Given this list of marker genes EREG, BMP15, TNFAIP6, GDF9, PTGER2, PTX3, BMPR1B, AREG, AMBP, here is a description of the gene set: studied in species Homo sapiens Human Gene Set: MATZUK_CUMULUS_EXPANSION from publication Matzuk MM, Lamb DJ (PMID 18989307) Reproduction is required for the survival of all mammalian species, and thousands of essential 'sex' genes are conserved through evolution. Basic research helps to define these genes and the mechanisms responsible for the development, function and regulation of the male and female reproductive systems. However, many infertile couples continue to be labeled with the diagnosis of idiopathic infertility or given descriptive diagnoses that do not provide a cause for their defect. For other individuals with a known etiology, effective cures are lacking, although their infertility is often bypassed with assisted reproductive technologies (ART), some accompanied by safety or ethical concerns. Certainly, progress in the field of reproduction has been realized in the twenty-first century with advances in the understanding of the regulation of fertility, with the production of over 400 mutant mouse models with a reproductive phenotype and with the promise of regenerative gonadal stem cells. Indeed, the past six years have witnessed a virtual explosion in the identification of gene mutations or polymorphisms that cause or are linked to human infertility. Translation of these findings to the clinic remains slow, however, as do new methods to diagnose and treat infertile couples. Additionally, new approaches to contraception remain elusive. Nevertheless, the basic and clinical advances in the understanding of the molecular controls of reproduction are impressive and will ultimately improve patient care. Genes important for cumulus expansion, based on mouse models with female fertility defects.